The following is a description of a gene set: S33 mutations of beta-catenin interfere with GSK3 phosphorylation and result in stabilization and nuclear localization of the protein and enhanced WNT signaling. S33 mutations have been identified in cancers of the central nervous system, liver, endometrium and stomach, among others. Reactome Pathway: CTNNB1 S33 mutants aren't phosphorylated part of: Signaling by CTNNB1 phospho-site mutants species: Homo sapiens, and this is the list of marker genes: PPP2R5D, PPP2R1B, PPP2R5C, GSK3B, AMER1, PPP2R5B, PPP2CB, CTNNB1, APC, PPP2R5A, PPP2R1A, PPP2CA, CSNK1A1, PPP2R5E (protein phosphatase 2 regulatory subunit B'epsilon), AXIN1